The following is a description of a gene set: species: Homo sapiens from publication Chen Y, Wang X (PMID 31504780) Human Gene Set: MIR548AC Genes predicted to be targets of miRBase v22 microRNA hsa-miR-548ac in miRDB v6.0 with MirTarget v4 prediction scores > 80 (high confidence targets)., and this is the list of marker genes: MLLT1, HELZ, ARAP2, SLC18B1, ATP2A2, CCNC, PMS1, ZBTB41, NCL, VSTM2A, AEBP2, RNF38, KCNJ2, HECTD2, C5orf24, SGCZ (NCBI Gene Id 137868), BPNT2, PDCD7, FANCC, ZDHHC21, GABPA, PXDN, MOSMO, ATF7IP, LRRC8C, B3GNT5, HNRNPC, SUPT3H, CSNK1G3, EGR3, PAN3, MFSD13A, ERBIN (erbb2 interacting protein), WNK3, TRIM28, IKZF2, MARK1, IL6, MAP3K3, KIAA0232 (KIAA0232), IL6R, AZIN2, RP2, MBNL3, USP24, BRD3, PITPNB, CIPC, TNRC6B, TMEM170B, MYEF2, KLF11, CDK14, MCL1, DUS4L, SETBP1, TSPAN3, RASD1, EMP2, SLF2, SEPTIN2, LIN28B, ZBTB21, CCDC14, KPNA4, SNX18, SAMD8, DYRK1A, RAPH1, ZNF566, MAP2K4, ADGRG2, FAT1, FIGNL1, XPR1, PDE1C, EPC1, SRP54, PM20D2, SON, NUFIP2, CCND2, ANKRA2, RB1CC1, CARF, CNOT7 (CCR4-NOT transcription complex subunit 7), SOCS6, MAML3, TOX3, SLC25A16, SBK1, RSPRY1 (NCBI Gene Id 89970), STXBP4, QTRT2, INO80D, RB1, ELMOD2, BPTF, TMPO, TSC22D2, DOCK10, RIF1, ZMYM3, SCUBE2, RBBP4, ZNF28, SMG7, TP53INP1, CCDC68, POLR1A, FKBP1A, MAP3K5 (NCBI Gene Id 4217), UBE2D1, SMIM7, IGF2BP2, DIS3L2, API5, ATXN7L3, TAF7L, ANKRD13C, CPEB1, RAF1, HOXD13, VAV2 (NCBI Gene Id 7410), NEK1, ZMPSTE24, UHMK1, MOB4, COX15, ANKS1A, KIAA0408, ZBTB34, HDAC4, LRRC58, YTHDF1, PI4K2B, DTNA, HOXB7, TMEM128, PIK3R3 (NCBI Gene Id 8503), CSNK2B, SERBP1, MXD1, SNRK, UBR5, CD47, DYRK2, AKT1, EIF1AX, NAA50, TRMT9B, RBL2, RBMS3, ETF1, UBN2, TCF7L2, SCAI, SLC2A13, YWHAZ, PLAGL2, YIPF4, BMPR1A, DND1, LOXL2 (NCBI Gene Id 4017), ACVR1C, MPZ, TGFBR1, CASC3, SMURF2, CMTM6, ERO1B, CRLS1, FKBP5, DCBLD2 (discoidin, CUB and LCCL domain containing 2), FHIP1A, MFSD14B, LANCL3, NDUFA4, PRMT1, SPATA31A1, PDSS2, SAR1B, RGPD1, MOB1B, ZNF207, CCZ1B, TMEM59 (transmembrane protein 59), SLC44A1, KIN, SETD7, RBM20, MCM9, VEZF1, BCOR, CTXN2 (cortexin 2), PTBP2, VCPIP1 (valosin containing protein interacting protein 1, NCBI Gene Id 80124), MARCKSL1, RICTOR, NAA35, LRFN3, UGCG, KRAS, GABRA4 (NCBI Gene Id 2557), ZBTB22, UHRF1, GPC6, KCTD12, NAMPT, FAM76B, STAC, USP42, PSD3, ERI1, CCDC71L, SHISAL1, IRX2, DCUN1D4, SPRED1, LSM14A, CYRIB, MCU, TLNRD1, CXCL12, SMIM10L1, PDCL3, USP38, ITPA, STOML2, DNMT1, ARID4A, HUWE1, BACH2, DNAJA2, ALKBH1, RASA2, BCL2L10, COL4A1, NOL7, RIT2, KDM2A, DNAJB11, DDX5, SEMA6D, TTC28, ZFAND4 (zinc finger AN1-type containing 4), C18orf54, BTBD10, PRKAA2, FSBP, ACBD5, LRRTM4, ATP2B2, ZNF148, YPEL5, HNRNPR (heterogeneous nuclear ribonucleoprotein R), ZBTB8A, ROR1, DMD, ING3, ENTPD7, CPNE8, RSBN1, PPP1R2, DDX6, LAMTOR1, SORCS1, SCG2, MED13, PDE7A, TMEM64, MLLT3, ADISSP, RSKR, DAG1, RSRC1, UTRN, ONECUT2, SCN9A, PRKAR2B, INPP4A, GORAB, TDRP, RBM27, EFEMP1, ZNF614, L2HGDH, PRDM4, SOAT1, AFF2, NTF3, SIAH2, PAPOLG, SPATA6, FMNL2, ZNF830, ARID1A, C2CD2, OTX2, ERGIC2, ZCCHC14 (zinc finger CCHC-type containing 14), SELENOI, PANK1, GPD2, PARP11, CACNA2D1, ELAVL1, TAF9, SPTSSA, ZNF529, KIRREL1, MMGT1, APH1A, SPATA31A3, MAPK1, TANK, NUP98, MID1, CNOT6L, HDX, MTRF1L, STX16, GPATCH2, IPO8, GFPT1, KDM7A, ZNF704, MARCHF5, HSPE1-MOB4, GRIN3A, ICAM5, MGARP, PITPNM3, MYC, FYTTD1, MATR3, RPS6KA3, ITPRIPL2, BCL2L11, CDK17, HYCC2, NPAS3, ERP44, TSPAN9, ZNF583, TUT4, NRIP1, DOCK6 (dedicator of cytokinesis 6), PTBP3, WDR44, B4GALT4, CD96, SETD3 (NCBI Gene Id 84193), DLG1 (NCBI Gene Id 1739), SPATA31A7, ARL6IP5, LRRC37B, ADARB2, COLGALT2, SIDT2, STOX2, CPSF6, SPATA31A5, SYT16, ROBO1, MAP3K7, RMI1, NAALADL2, EREG, GABBR2, LEPROTL1, CRY1, SNX12, SLC35A3, KRTAP2-4, PPP1R14B, MAFB, SLC30A7, SDK1, UBE2H, MDM4, PIK3R1, CCNYL1, SPIN1, PLGRKT, TUT7, PID1, MBTD1, RC3H1, IQGAP2, TCP11L2, COL1A1, PTPRZ1, PELI1, RCAN2, CADM2, FOXN2, STARD4, MFAP3L, GOLM2, SAP130, FZD6, TTC14, TBL1XR1, MAPK8, SMC1A, USP49, GSE1, CNOT9, RASEF, WWP1, MTMR4, SH3RF1, LLGL2, ARGLU1, WWC3, AGL, WNT5A, DNAL4, PHC3, RNFT2, AGPAT1, STIM2, CLP1, PRR14L, CREBRF, DNAJB1, FOSL2, ZNF800, CAMSAP2 (NCBI Gene Id 23271), SLC25A44, STRN3, SOS2, SOCS5, ZNF248, HDGFL2, ICE2, CPEB2, CA13, CCZ1, DOCK9, TMPRSS15, TET3, GTF2A1, OTUD7B, CHUK, TNFSF11, INVS, HSPH1, ARL6IP6, CSNK1A1, ZC3H12C, PITPNM2, FAM169A (NCBI Gene Id 26049), GIGYF1, MED1, MEX3C, SCYL2, CREBBP, BBS9, EGLN1, ABCC2, RCC1L, HUS1, BAG5, TRHDE, ZFAND5, HIPK2, YBX1, PLPP2, LETM2, DNMT3B, CCDC34, RBPJ, PSIP1, BARD1 (NCBI Gene Id 580), RETREG1, ANO3, XIAP, MEF2C, TLL1, GMCL1, ZFP30, HOXA5, TM2D3, MAPK6, ABI2, KMT2C, RBM46, SMC1B, PCDH20, ZNF875, ZMIZ1 (NCBI Gene Id 57178), B3GALT2, SPATA31A6, AHSA2P, PIK3CA, IER3IP1 (NCBI Gene Id 55392), AZIN1 (antizyme inhibitor 1), GABRG1 (gamma-aminobutyric acid type A receptor subunit gamma1), RETSAT, SKI, ARFGEF3, PUM2, GPR63, SYT4 (synaptotagmin 4), BOLL, AMFR (autocrine motility factor receptor), BROX, RUNDC3B, COPS2, CDS2, YTHDF3, TMEM131, ATP13A3, POLD3, SGO2, ABHD13, GNA11, SOX6, SASH1, TOX, TBCA, VGLL3, EIF4G2, PDS5A, LPGAT1, G2E3, ATP2B4, CABLES2, DNAJB4, ELOC, SYNCRIP, RABEP1, PELI2 (pellino E3 ubiquitin protein ligase family member 2), TMEM63B, YBX3, SSR1, TMC7, IDS, ANO5 (anoctamin 5), CAMTA1, ZNF648, GRIA2, RPS6KA6, LIN7C, ANKRD28, MYBL1 (NCBI Gene Id 649850), ZNF547, DCLK1, PPM1B, LARP4, GRPEL2, ARX, MYLK, NOL10, DNAJB12, TAOK1, DPY30, VKORC1L1, ZBBX, PRMT3, ATL3, ARHGAP29, TMCC1, KLHL15, LOXL1 (NCBI Gene Id 4016), PPP2R1A, TSLP, SUZ12, ZNF468, ETNK1, GNAI3, MSI2, FLI1, NOTCH2, RNPC3, FZD3, TFPI2, STK24 (NCBI Gene Id 8428), HOOK3, SEMA4B, TBX3, SLC10A4, UNC5D, RORA, POU3F1, ALK, PIM1, PTPRK, MBOAT2, MITF, FSD1L, SKIL, NAV2, USP16 (ubiquitin specific peptidase 16), SFPQ, HDAC8, PRKCI, FBXW2, GCFC2, HIF3A, AKAP10, MAGOHB, GTF3C4, ATP6V0A2, OSGEP, CNTLN, HOXD8, SOHLH2